Given this list of marker genes LRP10, SDC1, CLPS, APOB, RBP2, AGRN, AKR1B10, GPC3 (glypican 3), APOA4, SDC4, APOC3, RDH11, AKR1C4 (aldo-keto reductase family 1 member C4), APOM, RETSAT, RBP4, GPC4, APOE, APOA1, GPIHBP1, LRP1, GPC6, AKR1C1, LRP8, LPL, PLB1, LDLR, RBP1, SDC2, LRP12, APOA2, LRP2, APOC2, BCO2, HSPG2, TTR, LRAT, GPC1, GPC2, GPC5, AKR1C3, BCO1, PNLIP, SDC3, here is a description of the gene set: Vitamin A (all-trans-retinol) must be taken up, either as carotenes from plants, or as retinyl esters from animal food. The most prominent carotenes are alpha-carotene, lycopene, lutein, beta-cryptoxanthine, and especially beta-carotene. After uptake they are mostly broken down to retinal. Retinyl esters are hydrolysed like other fats. In enterocytes, retinoids bind to retinol-binding protein (RBP). Transport from enterocytes to the liver happens via chylomicrons (Harrison & Hussain 2001, Harrison 2005). Reactome Pathway: Retinoid metabolism and transport studied in species Homo sapiens part of: Metabolism of fat-soluble vitamins; Visual phototransduction